The following is a description of a gene set: studied in species Mus musculus electronically inferred by orthology from the curated human pathway This event has been computationally inferred from an event that has been demonstrated in another species.<p>The inference is based on the homology mapping from PANTHER. Briefly, reactions for which all involved PhysicalEntities (in input, output and catalyst) have a mapped orthologue/paralogue (for complexes at least 75% of components must have a mapping) are inferred to the other species. part of: Signaling by FGFR3 Reactome Pathway: Downstream signaling of activated FGFR3, and this is the list of marker genes: Shc1, Frs2, Fgf16, Gab1, Fgf23, Grb2, Fgf20, Fgf4, Hras, Fgf2, Fgf8, Fgf1, Fgf17, Fgf5 (fibroblast growth factor 5)